Given this list of marker genes Atp6v1b1, Lmx1b, Shank1, Lmx1a, Bbs1, Tpbg, Wfs1, Gjb4, Chd7, Drd4, Ubr3, Adcy3, Grin1, Cfap69, Gucy2d, Mup20, here is a description of the gene set: The behavior of an organism in response to an odor. species: Mus musculus Mouse Gene Set: GOBP_OLFACTORY_BEHAVIOR